The following is a description of a gene set: Mouse Gene Set: GOCC_KERATIN_FILAMENT species: Mus musculus A filament composed of acidic and basic keratins (types I and II), typically expressed in epithelial cells. The keratins are the most diverse classes of IF proteins, with a large number of keratin isoforms being expressed. Each type of epithelium always expresses a characteristic combination of type I and type II keratins., and this is the list of marker genes: Krtap16-1, Krt16, Krt10, Gper1, Krt7, Krt2, Krtap4-6, Krt25, Krtap26-1, Casp14, Krt14, Krtap3-3, Krt71, Krt18, Krt72, Csnk1a1, Krt82, Fbf1, Krtap9-3, Krt76, Krtap3-1, Krt36, Krt79, Fam83h, Krt81, Krt4, Krt74 (keratin 74), Krt73, Gm5414, Krt1, Krt75, Krtap3-2, Krtap12-1, Krt8, Krt86, Krt84, Krt80, Krt77, Krt83, Gm5478, Krt9, Krt5, Krt85, Krt87, Krt6a, Krt78, Krtap5-4, Krtap29-1, Krt13, Krt90, Krt6b, Tchp, Eppk1